The following is a description of a gene set: Mouse Gene Set: chr8E2 studied in species Mus musculus, and this is the list of marker genes: Capn9, Disc1, A630001O12Rik, Urb2, Tomm20, Ccdc7b, Rab4a, Ttc13, Gm9172, Abcb10, Kcnk1, Gm16163, Gm26427, Gm9204, Nrp1, Nup133, Irf2bp2, Gm26100, Tsnax, Gm6921 (NCBI Gene Id 638324), Fam89a, Arv1, Gm26397, Gm3889, 2810004N23Rik, Exoc8, Rbm34, Egln1, Gm38574 (NCBI Gene Id 102641752), Ccsap, Map10, Gnpat, Galnt2, 2810455O05Rik, Trim67, Gm32856, Pcnx2, Gm5358, 2310022B05Rik, Ccdc7a, Gm29773, Mir1903, Cog2, Ntpcr, Tarbp1, Coa6, A730098A19Rik, Gm17827, Pgbd5, Taf5l, Gm21399, Agt, Gm4342, Gm31718, Mir1967 (microRNA 1967), Gm22545, Gm45805, 4930567H12Rik, Sipa1l2, Map3k21, Mir21c, Sprtn, Acta1, Gm6091, 1810008B01Rik, Pard3, Gm24459, Slc35f3 (solute carrier family 35, member F3), Zfp1006, Itgb1